Given this list of marker genes MYO9B (NCBI Gene Id 4650), MRPS18C, CNDP2, PPP2R1A, MRPL11, HPF1, ZNF639, DUT, HADH, INPP5K, PDGFB, ORC6, NUP93, UPF3B, CD52, TENT2, CHD1, RAC1, PMVK, RRBP1, RGS16, NCBP2AS2, CKS2, CRYL1, EGLN3, UTP3, COPRS, RAP2C, MRPS35, ATP5MC2, GALE, MPG, MCRIP2, ENO2, JDP2 (NCBI Gene Id 122953), CTSV, EPOP, TAF5L, MARCKS, TCF19, CASP3, IFT57, MAD2L1, BOLL, CDK2AP1, MRPL12, FUT7, PTGS2, RPL24, RAB32, NR2C2AP (NCBI Gene Id 126382), NDUFS6, NELFE, PLTP, UBXN10, CDT1, UBE2C, SEMA4F, MIIP, CSTB, NIT2, PRDX4, SPO11, KLF10, PDLIM4, FXN, TRAK1, PTRHD1, NOP53, INCENP, SERPINB1, KIF2A, SAP18, BIN3, CYP39A1, PLXDC1, NDUFB11, ATP5PF, PDCD6, PHF7, TBCB, IFT46, PTPMT1, CAPZA2, CROCC, FAF1, ARIH2, PADI4, VRK1, JPT1, SSBP4, MID1IP1, NFKBIA, IL1R2, METTL1, NCMAP, NT5M, DCTN2, ATG7, EBPL, HMGB3, HLX (NCBI Gene Id 3142), COX6C, MX2, PGK1, SH3BGRL3, ASF1A, NDUFV3, NDUFB8, TXN, SLCO5A1, SDHD, ADRB2, PSMB2, NPC2, SYCE2, ITGB1BP2, TMEM160, COMMD4, MCRIP1, COMMD1, ACSL1, PRADC1, SFN (NCBI Gene Id 2810), COX7A2, NMB, RBBP8, XPO4, DDX10, ROMO1, LGALS1, CBFA2T2, VDAC1, KLHDC2, PRPF19 (NCBI Gene Id 27339), MARCKSL1, MT2A, MAFF, RAB6B, HGSNAT, EFHD2, CCR4, UHRF1, MED16, QPRT, CMPK1, PGRMC1 (progesterone receptor membrane component 1), CD99, FAM162A, EMD (emerin), AGTRAP, ING2, STMP1, ACTG2, MTMR7, MRPL57, ANKS1A (ankyrin repeat and sterile alpha motif domain containing 1A), AURKA, CDKN2C, ATP6AP2, OGFRL1, PINK1, CDC34, ZNF622, SLC13A3, HDDC2, ANAPC13, TAF9, ZNF593, ZBTB22, MRPL23, BANF1, MRPS28, COPS6, ETFB, TCEANC2, SCAND1, LDHA, DCXR, BIRC5, AHCY, ZNF277, RBMX, DAD1, UBE2L3, TIMP2, METTL9, BAG3, PYGL, GPR143, ERCC1, BRIX1, HAUS2, EMP3, ROGDI, BSCL2, MPC1 (NCBI Gene Id 51660), UFC1, PIK3CG, TIMM23, here is a description of the gene set: studied in species Homo sapiens from publication Darce J, Rudra D, Li L, Nishio J, Cipolletta D, Rudensky AY, Mathis D, Benoist C (PMID 22579475) Genes up-regulated in T reg (FOXP3+) cells from NOD mice: Foxp3-Fusion-GFP versus Foxp3-ires-GFP. The aim of this study was to quantify the impact of chimeric Foxp3-GFP protein on the Treg cell transcriptional program. Human Gene Set: GSE37605_FOXP3_FUSION_GFP_VS_IRES_GFP_TREG_NOD_UP